Given this list of marker genes Itga7, Rims2, Pak3, Abi2 (abl interactor 2), Ssna1, Lamc1, Actg1, Sec24b (NCBI Gene Id 99683), Crabp2, Wnt8a, Ache, Farp1, Pax6, Cdh12, Nkx2-1, Sema4f, Ist1, Matn1, Fam168b, Adam8, Rac2 (Rac family small GTPase 2), Epb41l3, Szt2, Rtn4, Msx1, Thbs4, Reln, Wasf3, Muc3a, Abl1, Nrxn1, Mag (NCBI Gene Id 17136), Gdnf, Fermt2, Acte1, Fgf13 (fibroblast growth factor 13), Nfia, Clic5, Hoxa13, Sema5a, Ppfia2, Tecta, Edn1 (endothelin 1), Ntn1, Il6, Syngap1, Sdc2, Ptn, Taok2 (TAO kinase 2), F11r, Dapk3, Nova2, Cdk5, Zic2 (NCBI Gene Id 57066), Nedd4l, Map3k13, Nlgn1, Bhlhe22, Zdhhc15, Hprt1, Cadm1, Hecw1, Crb1, Postn, Hoxa2, Stxbp5, Lrp1, Aplp1, Cxcr4, Skor2, Trpc6, Dcdc2a, Stau2, Cpne1, Tpbg, Nrn1l, Kndc1, Zranb1, Map3k1, Usp33, Mul1 (NCBI Gene Id 68350), Nrp2, Ptprz1, Cdkl5, App, Drd2, Zmym6, Evl, Cdc42se2, Cntn6, Sh3gl2, Dst, Ptk2, Fry, Map4k4, Ano1, Mycbp2, Snap91, Dmtn, Nog (NCBI Gene Id 18121), Igfals, Runx3, Spag6l, Llph, Gla, Gata3 (NCBI Gene Id 14462), Arhgef25, Ulk2, S100b, Dact1, Ptprm, Dlg4 (NCBI Gene Id 13385), Stk11, Rhoa, Coch, Cdk5r2, Sema4c, Fgr, Wdr36, Smurf1, Sipa1l1 (NCBI Gene Id 217692), Cyfip1, L1cam, Phip, Mef2a, Lamb3, Itga1, Fezf2, Cdh11, Vsig1 (V-set and immunoglobulin domain containing 1), Grip1, Clrn2, Amigo1, Epb42 (NCBI Gene Id 13828, erythrocyte membrane protein band 4.2), Ank3, C1galt1c1, Gas7, Ccl24, Boc, Cryaa, Epha7, Abi1 (abl interactor 1), Rap2a, Dip2b, Tet1, Sema6c, Itgb3, Parp6, Wasl, Ankrd27, Limd1, Idua, Dynlt1f, Afdn, Sult4a1, Fat1, Lzts3, Aplp2, Garin5b, Spg11, Ptprq (NCBI Gene Id 237523), Gna12, Lamc2, Cdh13, Nodal, Ndn, Tubb1, Ddr1, Ccl12, Bbs1, Shroom2, P2ry1, Nrn1, Zmpste24, Plppr4, Ryk, Dab2ip (NCBI Gene Id 98996), Rnd2 (NCBI Gene Id 11858), Spta1, Mecp2, Pou3f2, Cdh22, Mir9-3, Trak2, Islr2, Fmnl2, Cd2ap, Fgf8, Spast (NCBI Gene Id 54171), Adarb1, Mbp, Bdnf, Rilpl2, Efna5, Macf1, Enpp1, Igf2bp1, Flot1 (flotillin 1), Armc2, F2, Vpreb1a, Kel, Hnrnpk, Pdpn, Klf2, Rufy3, Slitrk3, Cfdp1, Coro1b, Brwd3, Ablim1, Spr, Prox1 (prospero homeobox 1), Arhgef26, Cdh10, Arhgap35, Gbx1, Gfra3, Esrrb, Edn2, Lmx1a, Ptprj, Celsr3, Anapc2, Adcy10, Robo1, Sgk1, Kdr, Cntnap1, Ubb, Triobp, Ccl11, Cdc42ep5, Gm14137, Plxnb2, Thoc2, Prdm14, Rnase10, Bmpr2, Rpl24, Tlx2, Cdh24, Il1rapl1, Prkdc, Rgma, Enah, Ptpro, Fblim1, Tanc2, Draxin, Raph1, Rock1, Nherf1, Arhgap18, Stxbp1, Nyap1, Arap1, Pdzd8, Nefm, Nfix, Hdac6, Fgd1, Garin5a, Isl2, Pxn, Wnt7b, Garin2, Ndel1, Magi1, Pcdh15, Ccr5, Dicer1, Ntng2, Lrrk2, Flrt3, Dnmbp, Cnmd, Tpm1, Cfap410, Rapgef2, Cux2, Septin7, Myo3a, Pls1, Ark2c, St14, Ccdc146, Ntn3, Negr1, Lgr4, Atxn2, Stc1, Ermn, Vasp, Aldoa, Shroom4, Pacsin2, Map2k1, Chl1, Ptprs, Diaph2, Tnfrsf12a, Slit3, Pitpna, Sema3f, Kifbp, Tbr1, Dab2, Zeb2, Cabp4, Pafah1b1, Pip5k1c (NCBI Gene Id 18717), Grem1, Gdi1, Itpka, Ngf, Cdc42ep3, Rac3, Ttl, Cul7, Il7r, Klf7, Cdh8, Xlr3b, Reg1, Mfap2, Hecw2, Zdhhc17, Hck, Pdzd7, Impact, Gprin3, Rdx, Sema6b, Gli3, Bcl11a, Slc25a46, Ncam1, Ctnna2, Mov10, Scrib, Tsc2, Rnf6, Eps8, Plxnd1, Ss18, Cdhr18, Efnb3 (ephrin B3), Prag1, Ezr, Emb, Lifr, Adam7, Kif5a, Ttc3, Vcl, Artn, Sox6, Evx1, Myh9, Ptch1, Ntf3, Slitrk1, Olfm1, Ccdc88c, Arhgap33, Disc1 (disrupted in schizophrenia 1), Icam1, Foxg1, Myl12a, Cdc42ep2, Sema3c, Atp2b2, Pkhd1, Sart3, Sema7a, Megf9, Foxp1, Ssh1, Psmb10, Tiam2, Nckap1, Prdm8, Ptprh, Pard3, Itgb1, Slc11a2, Syne3, Usp9x, Cspg5, Mgll, Ehbp1l1, Sema4d, Rilpl1, Sema3e, Plxna3, Ccdc39, Bcl7a, Prpf40a, Rhog, Lrrc4c, B4galt5, Marcks, Map1b, Ppp3ca, Ugt8a, Ighm, Ripor2, Tbcd, Lamc3, Etv4, Akap5, Dnm3, Shroom3, Vpreb1b, Ppp1r12c, Prkca, Tpm4, Lamb2, Cpne9 (copine family member IX), Rb1 (NCBI Gene Id 19645), Adgrb3, Skil, Myo3b (myosin IIIB), Lhx1, St8sia2, Kirrel3, Ndp, Plod3, Cnp, Nrp1, Lrp8, Gdf7, Cdh7, Bcl6, Grxcr2, Trak1, Ust, Flrt2, Lyn, Prickle1, Map1s (microtubule-associated protein 1S, NCBI Gene Id 270058), Ntrk1, Unc5c, Ntn4, Pak6, Uchl1, Trpv2, Syt17, Fitm2, Notch3, Brsk1, Slc30a1, Afg3l2, Cdh17, Mir200b, Ednra, Caprin2, Garin3, Top2b, Fat3, Zmym4, Arhgap15, Fbxo31, Adam10, Ccl7, Lama1, Nlgn3, Ppp1r9a, Rpl4, Ttc8, Rhou, Shtn1, Nbl1, Vps13a, Cldn3, Epha4, Unk, Actn1, Nyap2, Smarca4, Nexn, Epb41, Lama3, Bmpr1b, Ttyh1, Cacna1a, Cdc42, Dcaf17, Tnik, Cap1, Igf1r, Golga4, Aurka, Epha10, Nr4a2, Arc, Grk1, Kif5c, Neurog3, Vangl2, Dnaaf3, Cert1, Shox2, Palm3, Enam, Zswim6, Kit, Snap25, Fstl4, Med1, Rims1, Map2k2, Camk2a, Pof1b, Pdlim5, Wnt7a, Opa1, Map6, Trim46, Tunar, Actr2, B4galt6, Sema6a, Erbb2, Dscam, Lama2, Tbccd1, Rab8a, Mink1, Slc9a6, Cgn, Arhgap44, Dynlt1b, Pou4f2 (POU domain, class 4, transcription factor 2), Chrna7, Mfn2, Vps33a, Auts2, Or8a1b, Fzd4, Amotl2, Luzp1, Rasal1, Fes, Arhgef2, Numbl, Sema3g, Zfp365, Arhgap32, Tsku, Crk, Unc5d (unc-5 netrin receptor D), Cldn4, Slitrk4, Ulk1, Epb41l2, Efna1, Abitram, Dvl1, Itsn2, Id1, Sh3kbp1, Syt4, Nin, Slc1a3, Rock2, Nefh, Myo10, Syt2, Zfpm1, Bcl2, Zfp335, Stmn1, Dhx36, Pcdhac2, Clic4, Pecam1 (platelet/endothelial cell adhesion molecule 1), Cdh26, Strc, Tubb3, Scn11a, Nfatc4, Neurog2, Atg7, Ube3a (NCBI Gene Id 76097), Rbfox2, Kif1a, Tbce, Palmd, Notch1, Myh14, Rtn4rl1, Lef1, Ythdf1, Diaph1, Ngfr, Sema3d (NCBI Gene Id 74345), Bambi, Bin3, Rhoj, Plxnb1, Neo1, Rhpn1, Clec1b, Bhlhb9, Caprin1, Gap43, Dvl3, Gnat2 (NCBI Gene Id 99904), Ankrd24, Wasf2, Dcx, Cckar, Cdc42ep1, Apbb2, Myo9b, Srgap2, Cdkl3, Vdr, Cfl1, Actbl2, Tgfb2, Ptpn6, Pak1, Myh10, Alcam, Kif20b, Mapk14, Kif3a, Dlc1, Syt1, Wdr19, Slc23a2, Shank3 (NCBI Gene Id 58234), Cldn13, Cpne5, Mdk, Emx1, Mir124a-1 (microRNA 124a-1), Celsr2, Sh3glb1, Phox2b, Mapt (microtubule-associated protein tau), Mael (maelstrom spermatogenic transposon silencer), Stradb, Mettl3, Nbeal2, Wee1, Mt3, Unc93b1, Gja1, Arhgef18, Eif4g2, Trpc5, Cdh1, Cacna1f, Rab10, Cdk5r1, Ppp1r12a, Plxnc1, Dlx5, Asxl1, Dact2, Stk4, Braf, Whrn, S100a13, Cit, Arx, Gna13, Epha6, Rab25, Cdh4, Tnn, Isl1, Grhl2, Cyfip2, Fmnl3, Mark2, Ywhah, Abi3, Ptprf, Wasf1, Plxna1, Chrnb2, Lama5, Nrcam, Coro1c, Sipa1l3, Adcy1, Fgfr2, Cc2d1a (NCBI Gene Id 212139), Lmtk2, Kif21a, Sh3d19, Ppp1r12b, Pacsin1, Dscaml1, Tgfb1, Psen1, Sema4g, Ret, Dnm1l, Matn2, Eif2ak4, Wdr1, Myo5b, Tnr, Dcc, Ptprd, Xk, Wls, Vax1, Cfap418, Sparc, Adora2a, Cdc42se1, Cap2, Ush1c, Lats1, Klhl10, Tiam1, Epha2, Tubb2b, Abl2, Lst1, Hexa, Cib1, Col18a1 (NCBI Gene Id 12822), Rhobtb1 (Rho-related BTB domain containing 1), Efnb2, Twf2, Gli2, Rere, Thoc5, Mir200a, Fam171a1, Grcc10, Nr2e1, Apc, Cdh15, Kidins220, Rhoq, Ap3b1, Mir200c, Parvg, Dpysl5, Nsmf, Wdr47, Ptk2b, Efna2, Ilk, Lrp6, Anxa7, Dixdc1, Vps54, Atf4 (activating transcription factor 4), Ephb2, Efnb1, Strip1, Nckap1l, Pou4f3, Adam17, Hrh2, Actr3, Fgfr3, Adnp, Gas2, Sox17, Cdh3, Pias2, Nfib, Ift88 (intraflagellar transport 88), Vldlr, Atp9a, Myo9a, Dubr, Unc5b, Anxa1, Nefl, Barhl2 (NCBI Gene Id 54444), Fosl2, Ephb3, C9orf72 (C9orf72, member of C9orf72-SMCR8 complex), Hgf, Lpar1, Ephb6, Nf2, Cfap70, Prmt3 (protein arginine N-methyltransferase 3), Cdh23, Metrn, Pakap, Spi1, Mpig6b, Myo7a (myosin VIIA), Sidt2, Srf, Kank1, Strip2, Hpn, Actb, Dock7, Frmd6, Gas1, Ngef, Lgi1, Mef2c (myocyte enhancer factor 2C), Nell2, Palm, Nectin1, Thy1, Msn, Cdh19, Rtn4r, Abi3bp, Itga4, Slit1, Arpin, Nes, Iqgap1, Grxcr1, Robo3 (roundabout guidance receptor 3), Cttn, Dbn1, Rreb1, Atoh7, Nox4, Kalrn, Mapk8, Ect2, Plekho1, Tctn1, Mkln1, Jmjd1c, Nedd4, Gata1, Tmem106b, Golga2, Dag1, Vax2, Crppa, Cacng7, Ss18l1, Rabl2 (RAB, member RAS oncogene family-like 2), Dvl2, Dmrt1, Mir9-1, Als2, Hexb, Slit2 (slit guidance ligand 2), Apoe, Ntrk2, Ext1, Bcl11b, Mpl, Vil1, Eif2b2, Dkk1, Fgd4, Csnk1a1, Kdm1a, Camsap1, Rhobtb2, Chrna3, Ythdf2, Sema4b, Shh, Sema3a, Apbb1, Slitrk6, Sarm1, Snx2, Srcin1, Cdc42ep4, Nek3, Bap1 (Brca1 associated protein 1), Wnt5a, Ypel4, Chodl, Col25a1, Lmo4, Ntrk3, Dbnl, Add1, Sema6d, Cxcl12, Dnm2, Cfap44, Wtip, Fezf1, Clasp2, Plxnb3, Fzd3, Nfasc, Flnb, Sprr1b, Gbx2, Ctnnd2, Cdh18, Parvb, Dynlt1a, Ccl3, Dmd, Gpm6a, Larp4, Lratd1, Cdh2, Pten, Bcan, Parva, Stk25, Or10a4, Myot, Foxd1, Egfr, D130043K22Rik, Dlg1, Notch4, Myl12b, Arl13b, Klk8, Itgb6, Creb1, Spag9, Lpar3, Atoh1, Lrp4, Slc26a5, Brwd1, Nptx1, Hps1, Mfsd2a, Ep300, Trio, Rab21, Robo2, Sod1, Tsc22d4, Jade2, Coro1a, Etv1, Plxna4, Kif5b, Lrp2, Vegfa, Cdh6, Bves, Omg, Rab3a, Gorasp1, Limk1, Dock10, Mir376a, Zfp385a, Fryl, Ostn, Btbd3 (NCBI Gene Id 228662), Pmp22, Lipa, Smn1, Egr2, Sptbn4, Cd44, Garem2, Gm2990, Vim, Foxb1, Dtnbp1, Edn3, Poc1b, Ephb1, Id2, Bsg, Efna4, Rest, Mir9-2, Mir205, Picalm (phosphatidylinositol binding clathrin assembly protein), Smad4, Tbc1d24 (NCBI Gene Id 224617), Wnt3, Prkg1, B3gnt2, Lncbate1, Cylc1, Mnx1, Megf8, Cobl, Otx2, Phactr1 (phosphatase and actin regulator 1), Col6a1, Gje1, Prkn, Pak2, Bcl9l, Ptprv, Prtg, Map7, Baiap2, Sprr2a1, Atp8a2, Llgl1, Ift56, Map2, Mfn1, Spint2, Dip2a, Mypn (NCBI Gene Id 68802), Src (Rous sarcoma oncogene), Snx1, Brsk2, Dclk1, Tmem108, Arhgef28, Dynlt1c, Agrn, Ophn1, Garin4, Nrdc, Spart, Gp1ba, Ntn5, Cck, Ptpn11 (protein tyrosine phosphatase, non-receptor type 11), Plec, Lamb1, Zmym3, Slitrk2, Epha5, Sin3a, Shank1, Grin1, Lhfpl5, Myo16, Scn1b, Bmp7, Cdh5, Met, Spg21, Nrg1, Nkx2-9, Ahr, Wnt3a, Nr4a3 (NCBI Gene Id 18124), Ntf5, Drgx, Flrt1, Fn1, P2rx7 (NCBI Gene Id 18439), Mapk8ip3, Sema5b, Tal1, Smo, Fyn, Lhx9, Mir96, Tnmd, Slitrk5, Cntnap2, Camk2b, Ar, Slc39a12, Kif13b, Cntn1, Ago4, Kifc2, Nkx6-1 (NCBI Gene Id 18096), Nptn, Epha8, Lhx3, Enpp2, Shroom1, Lhx2, Tbc1d20, Numb, Rac1, Tuba1a, Cpne6, Spag6, Tprn, Prex2, Obsl1 (obscurin-like 1), Cfap43, Mir124a-2, Elavl4, Sema3b, Cux1, Arhgap4, Hes1, Capzb, Epha3 (NCBI Gene Id 353311), Upk3a, Atg16l1, Sema4a, Ntng1, Plaa, Itpr1, Atp7a, Ifrd1, Zfyve27, Map1a, Npr2, Unc13a, Dab1, Cask, Gsk3b, Pqbp1, Pla2g10, Eef2k, Wdpcp, Atl1, Lif, Slc39a3, Cul3, Prkcz, B4gat1, Lats2, Chn1 (chimerin 1), Fxn, Cdhr1, Clstn3, Heg1, Cntn5, Ece1, Odad3, Syt3, Ctnnb1, Unc5a (NCBI Gene Id 22251), Hoxa1, Mapk8ip2, Cdh20, Fmnl1, Efna3, Fbxo45, Tfcp2l1, Clu, Rnf157, Lhx4, Cntn2, Palld, Yap1, Csf1r, Flna, Fbxw8, Arhgdia, Ihh, Taok3, Crygb, Cdh9, Epb41l5, Lzts1, Clrn1, here is a description of the gene set: species: Mus musculus The developmental process in which the size or shape of a cell is generated and organized. Mouse Gene Set: GOBP_CELL_MORPHOGENESIS